The following is a description of a gene set: Activation of activator protein 1 (AP-1) and nuclear factor kappaB (NFkappaB)-dependent transcription is required for tumor promotion in cell culture models and transgenic mice. Dominant-negative c-Jun (TAM67) blocks AP-1 activation by dimerizing with Jun or Fos family proteins and blocks NFkappaB activation by interacting with NFkappaB p65. Two-stage skin carcinogenesis experiments in a model relevant to human cancer risk, transgenic mice expressing human papillomavirus 16 E7 oncogene (K14-HPV16-E7), show E7-enhanced tumor promotion. A cross to K14-TAM67-expressing mice results in dramatic inhibition of tumor promoter-induced AP-1 luciferase reporter activation and papillomagenesis. Epithelial specific TAM67 expression inhibits tumorigenesis without affecting TPA- or E7-induced hyperproliferation of the skin. Thus, the mouse model enriches for TAM67 targets relevant to tumorigenesis rather than to general cell proliferation or hyperplasia, implicating a subset of AP-1- and/or NFkappaB-dependent genes. The aim of the present study was to identify target genes responsible for TAM67 inhibition of DMBA-TPA-induced tumorigenesis. Microarray expression analysis of epidermal tissues revealed small sets of genes in which expression is both up-regulated by tumor promoter and down-regulated by TAM67. Among these, cyclooxygenase-2 (Cox-2/Ptgs2) and osteopontin (Opn/Spp1) are known to be functionally significant in driving carcinogenesis. Results identify both Cox-2 and Opn as transcriptional targets of TAM67 with CRE, but not NFkappaB sites important in the Cox-2 promoter and an AP-1 site important in the Opn promoter. Human Gene Set: MATTHEWS_SKIN_CARCINOGENESIS_VIA_JUN studied in species Mus musculus from publication Matthews CP, Birkholz AM, Baker AR, Perella CM, Beck GR Jr, Young MR, Colburn NH (PMID 17363560) Genes up-regulated by skin tumor promoters but completely blocked by expression of TAM67, a dominan-negative form of JUN., and this is the list of marker genes: SPRR2A, TRADD, CAAP1, FPR2, IGHD, AHNAK, LAMA3, ALOX5AP, PLAUR, GUCA2A, SPP1, CES2, CALML3, NCF2, RARG, ERO1A, IL36B, MUSTN1